Given this list of marker genes HOOK2, SOX6, TUBB6, ARNT, LUC7L3, NIPBL, SLC25A4, EHD3, ZNF689, IKZF2, LHX4, KLKB1, UBE2I, HOOK1, USP1, HEY1, BLMH, TFRC, GPR15, NIT2, ZNF454, ARSI, MRPL51, HIPK2, ELOVL5, ZNF274, PCDHB15, CHRNB4, PSMC2, TRABD2B, RASSF5, STAP1, YIPF6, SNRK, PDE7B, DIO3OS, VN1R5, SIRT5, ST18, RAN, VARS1, BRD8, GPRASP3, MYO1D, MUSTN1, TSN, PNMA1, ASPHD2, KLK8, ZMYM4, IRX5, SLC14A2, ZHX1, HLTF (helicase like transcription factor), RNF128, ZNF467, LPXN, SESN3, CTBP2, PCBP1, NFX1, MOV10, TLR5, LYRM7, TTC3, KLHDC7A, MAGT1 (magnesium transporter 1), ATP8A2, ACP3, IL20RA, SGSM1, PRRT1, BRCA2, DRC1, PLXDC2, TMEM63C, TNFAIP8, PGS1, DSC1, SAXO2, PABPC4, LBP, TRMT9B, PPP1CC, NHLRC1, ABHD8, CDON, SPATA4, NUP133, LEAP2, SLC38A3, N4BP2, VEGFD, IGFBP5, RNF169, PEX11G, S100A4, ARG1, IPO7, CCSAP, LIPN, PRL, PFKM, ADAM12, GNAS-AS1, PACSIN1, RFTN1, SSBP1, IGDCC4, ADAMTSL4 (NCBI Gene Id 80075), RFC4, LTA, OVOL2, SH2D5, MYLK, PCNP, ITM2C, FAM114A2, MROH9, KHDRBS3, SMCO3, ARTN, TRIM32, ELP4, SLC2A13, CEP135 (NCBI Gene Id 9662), RPN1, STK39, DDC, FAM43A, INPP4B, ST8SIA4, NAT14, TMEM176B, LIAS, SUSD2, IL7R, LRRC24, TFDP1, RNF213, MCTP1, RETREG1, TP53INP1, C6orf136, RNASE2, TACC2, EBF2, ADAD1, AAK1, REN, SEPTIN8, TPST1, TCF7, CDX1, ZC3HAV1L, SPARCL1, PRTN3, IL21R, PDK1, ANO3, EFL1, ATPAF1, ZSCAN10, CXADR, LRRC49, RTP4, SLC20A2, FNTA, AP2B1, SNAP47, THOC2, NEDD9, BNIP5, E2F6, TG, MLEC, OPA1, SLC6A14, COTL1, CRTAM (NCBI Gene Id 56253), PSD2, PRPH2, CD93, TCAF1, TNNI1, YPEL2, PAIP2, HES1, NUP188, DAAM2, ALOX15B, C2orf49, SOX30, NDUFA10, NSG2, ADGRG3, PNISR, GPATCH4 (G-patch domain containing 4 (gene/pseudogene)), KLHL9, IL17RB, here is a description of the gene set: species: Homo sapiens Previous reports have defined three subsets of mouse NK cells on the basis of the expression of CD27 and CD11b. The developmental relationship between these subsets was unclear. To address this issue, we evaluated the overall proximity between mouse NK cell subsets defined by CD27 and CD11b expression using pangenomic gene expression profiling. The results suggest that CD27+CD11b-, CD27+CD11b+ and CD27-CD11b+ correspond to three different intermediates stages of NK cell development. Human Gene Set: GSE13229_IMM_VS_MATURE_NKCELL_UP Genes up-regulated in comparison of immature NK cells versus mature NK cells. from publication Chiossone L, Chaix J, Fuseri N, Roth C, Vivier E, Walzer T (PMID 19234143)